The following is a description of a gene set: studied in species Mus musculus Mouse Gene Set: GOBP_PARENTAL_BEHAVIOR A reproductive behavior in which a parent cares for and rears offspring., and this is the list of marker genes: Pten, Hcn1, Oxt, Avpr1a, Kalrn, Npas3 (neuronal PAS domain protein 3), Drd1, Avp, Zfx, Nr3c1, Oprk1, Oxtr, Fev, Dbh, Crebrf, Prl, Gal, Gnaq, Mbd2, Npas1, Brinp1